The following is a description of a gene set: from publication Zaslavsky E, Hershberg U, Seto J, Pham AM, Marquez S, Duke JL, Wetmur JG, Tenoever BR, Sealfon SC, Kleinstein SH (PMID 20164420) The dendritic cell (DC) is a master regulator of immune responses. Pathogenic viruses subvert normal immune function in DCs through the expression of immune antagonists. Understanding how these antagonists interact with the host immune system requires knowledge of the underlying genetic regulatory network that operates during an uninhibited antiviral response. In order to isolate and identify this network, we studied DCs infected with Newcastle Disease Virus (NDV), which is able to stimulate innate immunity and DC maturation through activation of RIG-I signaling, but lacks the ability to evade the human interferon response. To analyze this experimental model, we developed a new approach integrating genome-wide expression kinetics and time-dependent promoter analysis. We found that the genetic program underlying the antiviral cell state transition during the first 18-hours post-infection could be explained by a single regulatory network. Gene expression changes were driven by a step-wise multi-factor cascading control mechanism, where the specific transcription factors controlling expression changed over time. Within this network, most individual genes are regulated by multiple factors, indicating robustness against virus-encoded immune evasion genes. In addition to effectively recapitulating current biological knowledge, we predicted, and validated experimentally, antiviral roles for several novel transcription factors. More generally, our results show how a genetic program can be temporally controlled through a single regulatory network to achieve the large-scale genetic reprogramming characteristic of cell state transitions. Human Gene Set: GSE18791_UNSTIM_VS_NEWCATSLE_VIRUS_DC_18H_UP species: Homo sapiens Genes up-regulated in comparison of control conventional dendritic cells (cDC) at 18 h versus cDCs infected with Newcastle disease virus (NDV) at 18 h., and this is the list of marker genes: NIP7, PHF10, FAH, CAMK1, SLC24A4, HSBP1, PCYOX1, TGFBR2 (transforming growth factor beta receptor 2), GAS6-DT, FAM98A, ZBTB8A, HS3ST1, ZPR1, SNX29, DLG1-AS1, METTL25, TUBA4A, SCYL1, CLTC, ELMOD2, ZSWIM7, UBE2NL, MAOA, ANKRD54, DPP3, ZYG11B, PPIP5K1, SEH1L, LCLAT1, SLCO2B1, PAK2, TIAM1, ZYX, PITPNA, CIITA, MTARC1, NUP155, RANBP10, COQ9, REM2, EFCAB14, HOTAIR, CHST14, MRPL41, GCOM1, UNG, PCBD2, ZNF850, ACTL6A, NCBP1, CASD1, BCR, PLK4, WDR1, P4HTM, SLC25A19, ZNF322, TUBB6, NDUFA8, MRTFB, MRPS18B, PITPNM1, DRG1, TRAK2, PKIA (cAMP-dependent protein kinase inhibitor alpha), DDX56, PWP2, BMS1, PRPF8, SLX4, CSRP1, ST7, KIAA0586, NVL, CNPY3, ADHFE1, CAB39, IL21R, PEX11A, INPP5K, PMPCA, HMOX2, NACC2, MRPL45, EIF2B2 (eukaryotic translation initiation factor 2B subunit beta), PRKDC, ALG14, TMEM45B, DNAJC11, TEX261, ERH, TRAPPC12, NNT, FBXO45, PTGR1, NIPSNAP2, MOB3A, KRT6A, PSMB6, TTL, APRG1, SLC25A3, MYOCD, EXOSC7, STRAP, RRAGB, GPN1, TRAM2, ERCC3, PPCDC (NCBI Gene Id 60490, phosphopantothenoylcysteine decarboxylase), PPP1R35, PCGF6, SIGIRR, HIP1, NDUFA5, IL16, UBE4B, PIGU, DMAP1, MILR1, C2CD2L, SLC30A5, DAAM1, ZBED10P, DACH1, G2E3, ZFYVE19, SLC39A3, PTK2, TTC8, WDR37, ENTPD7, MBTPS1, EBNA1BP2, NCOR1, DNAAF10, ZNF248, MTMR14, PHAX, INTS1, GPAM (glycerol-3-phosphate acyltransferase, mitochondrial), TCP1, ARL2BP, TIMM17A (NCBI Gene Id 10440), HECTD1, TOLLIP, B3GAT3, LAMC1, NCKAP5, ZFYVE21, RIDA (NCBI Gene Id 137671), DFFA, HDAC2, SMARCC1, CETN2, IVD, GPSM2, WDR3, ZNF542P, MRPL22, PRPS1, CDCA7, ZNF823, MRPS6, ITGB1BP1, ROCK2, NAT10 (NCBI Gene Id 79715), PLTP (NCBI Gene Id 5360), TBCD, PET117, MED22, ACAD8, CAMK2G, CD84, RUNX1, STRADB, TOMM40L, AMFR, MTIF3, B4GALT3, RFC5, DPH5, RFNG, ATP5F1D, YRDC, INTS7, NELFCD, UNC45A, ZNF251, CRH, ARHGEF6, CDCA7L, HECTD3, GFUS, UBL7-DT, MYC, IGF1R, MIPEP